The following is a description of a gene set: part of: Nuclear events mediated by NFE2L2 Reactome Pathway: NFE2L2 regulating ER-stress associated genes Subpathway representing ER-stress-associated genes regulated by NFE2L2 (NRF2). Activating transcription factor 4 (ATF4) is a stress-induced transcription factor that is frequently upregulated in cancer cells. ATF4 controls the expression of a wide range of adaptive genes that allow cells to endure periods of stress, such as hypoxia or amino acid limitation. However, under persistent stress conditions, ATF4 promotes the induction of apoptosis. ATF4 is also known to regulate serine and glycine biosynthesis in NSCLC species: Homo sapiens, and this is the list of marker genes: MAFK, EP300 (E1A binding protein p300), CREBBP, NFE2L2 (NFE2 like bZIP transcription factor 2), ATF4